The following is a description of a gene set: Human Gene Set: MODULE_245 species: Homo sapiens Genes in the cancer module 245., and this is the list of marker genes: CCT4, ATF6, TNPO1, SRP9, SSR2, HSPA8, AOC1, BAG3, HSPD1, TOMM34, SSR1, KPNA2, HSPE1 (NCBI Gene Id 82869), PPIC, KDELR1, CCT6A, ERP29, KPNB1, TNPO2, PDIA5 (NCBI Gene Id 10954), LRPAP1, FKBP1A, PDIA6, DNAJA1, VBP1, KDELR2